Given this list of marker genes BBOX1, TMLHE, ALDH9A1, ACADM, SHMT1, here is a description of the gene set: Human Gene Set: GOBP_CARNITINE_BIOSYNTHETIC_PROCESS The chemical reactions and pathways resulting in the formation of carnitine (hydroxy-trimethyl aminobutyric acid), a compound that participates in the transfer of acyl groups across the inner mitochondrial membrane. studied in species Homo sapiens